Given this list of marker genes STN1, SMPD1, XYLT1, HLA-DRB1, DSP, MUC5B, ABCC6, ATP11A, SFTPA1, EIF2AK4, DPP9, NDUFAF6, POT1, RTEL1, CSF2RA, FAM13A, ABCA3, SFTPC (surfactant protein C), TINF2, XYLT2, TERT, SFTPA2, SERPINA1, COPA, PARN, TERC, here is a description of the gene set: An abnormal amount of oxygen passes into the blood from the lungs and/or an abnormal amount of carbon dioxide passes from the blood into the lungs. Human Gene Set: HP_ABNORMAL_DLCO species: Homo sapiens Abnormal DLCO